The following is a description of a gene set: Genes positively differentially expressed in cell type: Treg upon treatment with cytokine: IFN-α1 in mouse lymph nodes in vivo. species: Mus musculus from publication Cui A, Huang T, Li S, Ma A, Pérez JL, Sander C, Keskin DB, Wu CJ, Fraenkel E, Hacohen N (PMID 38057668) Mouse Gene Set: CUI_TREG_IFNA1_RESPONSE_UP Cytokines mediate cell-cell communication in the immune system and represent important therapeutic targets. A myriad of studies have highlighted their central role in immune function, yet we lack a global view of the cellular responses of each immune cell type to each cytokine. To address this gap, the authors created the Immune Dictionary, a compendium of single-cell transcriptomic profiles of more than 17 immune cell types in response to each of 86 cytokines (>1,400 cytokine-cell type combinations) in mouse lymph nodes in vivo. A cytokine-centric view of the dictionary revealed that most cytokines induce highly cell-type-specific responses. For example, the inflammatory cytokine interleukin-1β induces distinct gene programmes in almost every cell type. A cell-type-centric view of the dictionary identified more than 66 cytokine-driven cellular polarization states across immune cell types, including previously uncharacterized states such as an interleukin-18-induced polyfunctional natural killer cell state., and this is the list of marker genes: Oasl1, Tut4, Hmgn3, Rtp4, H2-Q6, Parp10, Tapbp, Sell, Cmpk2, Gadd45g, Ifi214, Vcpip1, Max, Oas1a, Psme1, Apobec3, Iigp1, Mvb12a, Pcgf5, Trim25, Parp11, Mycbp2, Ube2l6, Hspa5, Slc25a28, Slfn1, Ppa1, Zbp1, Uba7, Socs1, Tmbim6, Snx2, Dhx58, Parp14, Gbp4, Tcstv4, H3f3b, Rnf213, Svbp, Hsh2d, Mxd1, Gng12, Adar, Pml, Ifi213, Aida, Nlrc5, Ifi47, Xaf1, Bbx, Il2rb, Etv6, Gbp3, Slco3a1, Gbp7, Ascc3, Usp18, Mrpl30, Oas3, Zup1, Trim56, Cybb, Ifitm3, Tasor2, Rsad2, Macroh2a1, Vps54 (NCBI Gene Id 245944), Phf11c, Ccrl2, Ifi27l2a, Sp100, Cxcl10, H2-T22, Xdh, Itm2b, Gbp9, Npc2, Sp110, Nsd3, Eif2ak2 (eukaryotic translation initiation factor 2-alpha kinase 2), Shisa5, Ifi204, Irgm2, Irf7, Pttg1, Jaml, Isg15, Zc3hav1, Ifi209, Lag3, Ddx24, Parp9, 9930111J21Rik2, Parp12 (NCBI Gene Id 57885), Sp140, Sgcb, Vars1, Psme2b, Il12rb1, Ehd3, Rigi, Dbnl, Phf11a (NCBI Gene Id 71191), Tbrg1, Ogfr, Igtp (interferon gamma induced GTPase), Stat1, Ms4a4c, Mx1, Phf11b, Tap1, Hspa8, Atp8a1, Ppp1r12a, Slc14a1, Phip, Sdc3, Trim34a, Gbp5, Dtx3l, Eif1a, Serpina3g, Ifi44, Fchsd2, Ncoa7, Pdia3, Ifit1, Lgals3bp, Tor3a, Tspan3, Trim30d, Casp8, Tgtp2, Stat3, Asb13, Idnk, Ms4a4b (NCBI Gene Id 60361), Trim30c, Pmepa1, Stat2, Csrp1, Cd47, Nampt, Slamf7, Helz2, Tmsb10, Smchd1 (NCBI Gene Id 791279), Aftph, Ifi208, Dpp4, H2-K1, Chmp4b (NCBI Gene Id 96954), Rfc3, Arf4, Tcof1, Cnp, Itpr1, Fnbp4, Nt5c3, Psmb10, Ubc, Mitd1, Plaat3, H2-T23, Usp25, Cd86, Daxx, Dnajc13, Samhd1, Gbp8, Ifih1, Laptm4a, Slfn2, Trim12a, Cd2, Ifit3b, Capza2, Ly6a, Cish, Ctss, Mndal, Slc25a22, Socs3, Atg13, Trim21, Herc6, Ddx60, Tspo (NCBI Gene Id 12257), Tap2, Ifit2, Slfn5, Ms4a6b, Trim12c, Ifi203, H2-Q4, H2-D1 (histocompatibility 2, D region locus 1), Ifit3, Isg20, Etnk1, Gbp2, Irf1, Psme2, Tor1aip2, Tmem184b, B2m, Psmb2 (proteasome (prosome, macropain) subunit, beta type 2), Slfn8, Ifi206, Ccnd2, Psmb9, Psmb8, Ly6e (lymphocyte antigen 6 family member E), Ifi35, Rnf114, Mov10, Rnf139, H2-Q7, Irf9, Atp10a, Ifit1bl1, Treml2, Trafd1, Irgm1, Trim30a, Clic4, Naa20, Sla, Epsti1, Cd274, Samd9l, Gbp6, Lgals9, Oasl2, Trim26, Selenow, Bst2, Znfx1, Nmi, Cep57l1